Given this list of marker genes RAP2A, CDC42, NHERF1, SCRIB, MSN, PTK7, IFT20, DLG5, FOXF1, TP63, RHOA, SYNE4, CAMSAP3, TCF15 (transcription factor 15), WNT5A, OPHN1, SH3BP1, AJAP1, EZR, RAB10, ZDHHC7, YAP1, TTC8, FAT1, AHI1 (NCBI Gene Id 54806), LAMA1, MYO9A, here is a description of the gene set: Human Gene Set: GOBP_POLARIZED_EPITHELIAL_CELL_DIFFERENTIATION The process in which a relatively unspecialized cell acquires specialized features of a polarized epithelial cell. The polarized epithelial cell can be any of the cells within an epithelium where the epithelial sheet is oriented with respect to the planar axis. species: Homo sapiens